Given this list of marker genes CNOT2, HOXD13, IFT43, APC2, CNTNAP1, MEIS2, SLC12A6, KDM5A, SETD5 (SET domain containing 5), BMP2, FDFT1, TRIO (trio Rho guanine nucleotide exchange factor), MAPRE2, PUF60, ARMC9, SLC12A2, BCOR (BCL6 corepressor), RBPJ, TBX15, TBCK, SHMT2, BMPR1B, SYT1, ARCN1, ADNP, EBP, GNE, MYCN, PHIP, FGFR2, POLR3A, JARID2, MED25, SHANK3, NEDD4L, NOG, CLCF1, HEPHL1, TAF4, TTI2, AP1G1, ALDH1A2, PIGY (NCBI Gene Id 84992), UBE2A, SMAD4, NSD1, PDE6D, MAN1B1, CSGALNACT1, FBXW11, KCNJ2, KCTD1, DDX11, NBN, SOX5, PLAAT3, BHLHA9, DDX6, TP63, IL11RA, IFT172 (intraflagellar transport 172), RAD21, STAG1, CERT1 (NCBI Gene Id 10087), CTCF, MEF2C, MAB21L2 (mab-21 like 2), CEP55, BBS7, TXNL4A, SALL1, ZMIZ1, MYRF, KMT2A, LMBR1, RALA, FGFR1, WDPCP, DHCR7, CDC45, ITPR1, RAI1, SMC3, NIPBL, SATB1, H4C9, KCNJ5, TRMT5, KMT2B, SIK3, GDF5, here is a description of the gene set: Human Gene Set: HP_2_3_TOE_SYNDACTYLY 2-3 toe syndactyly species: Homo sapiens Syndactyly with fusion of toes two and three.